The following is a description of a gene set: studied in species Mus musculus Any process that modulates the frequency, rate or extent of Schwann cell migration. Mouse Gene Set: GOBP_REGULATION_OF_SCHWANN_CELL_MIGRATION, and this is the list of marker genes: Rras2, Lrp1, Grin1, Tiam1, Rras, Fubp1, Cers2, Vim, Ptprz1, Nf1, Fas (NCBI Gene Id 14102)